The following is a description of a gene set: Human Gene Set: WP_CARDIAC_HYPERTROPHIC_RESPONSE Cardiac hypertrophic response species: Homo sapiens, and this is the list of marker genes: IKBKB, MAP3K7, NPPA, TGFB1 (transforming growth factor beta 1), MAP2K2, TGFBR1, PRKCA, MAP3K1, CDK7, AKT1, CALM1, NFATC2, FGFR2, TNFRSF1A, MAPK14, MAP2K4, EGF, IKBKE, HDAC5, PDPK1, MAP2K3, MAP3K14, PPP3CA, MAP2K5, MEF2A, MAP2K7, HDAC9, AKT2, MAP2K1, MAPK3, MAPK7, MAP2K6, HDAC7, CHUK, MAP4K1, GUCA1ANB-GUCA1A, FGF2, IKBKG, CDK9, TNF, PRKG1, PRKD1, MAPK8, CAMK2D, MTOR, NFKB1, RAF1, RAC1, PLA2G2A, NRG1, IGF1, GSK3B, GUCA1A, MAPK1, HDAC4